Given this list of marker genes RFLNA, SMAD3, NELL1, BMPR2, SOX9, BMP2K, SLC20A2, ECM1, ALOX5, AMTN, NOTCH1, MGP, ADGRV1, DMP1, TENT5A, TXLNG, ISG15, STATH, COMP, ROCK1, BMP2, WNT4, LTBP3, CEBPB, CCL3, BMP7, BCOR, ZMPSTE24, SRGN, FZD9, HEY2 (NCBI Gene Id 30830), TGFB1, PTN, CCN1, BMP4, ACVR2B, VDR, PHOSPHO1, PTK2B, GATA1, WNT10B, HEY1, BGLAP, LTF, RFLNB, KL, ADRB2 (adrenoceptor beta 2), ASPN, MATN1, CFTR, TWIST1, MIR208A, CYP27B1, ODAPH, ANKH, FAM20C (FAM20C golgi associated secretory pathway kinase), MEF2C, PKDCC, BMPR1B (bone morphogenetic protein receptor type 1B), AHSG, ACTN3, ENAM, NBR1, BMP6, ROCK2, MMP20, OSR2, ATP2B1, RXRA, SLC8A1, ENPP1, ATF4, ACVR1, NOTUM, OSR1, ADGRG6, SGMS2, DDR2, TRPM4, SLC4A2, NOS3, HIF1A, GAS6, ACVR2A, S1PR1 (sphingosine-1-phosphate receptor 1), PTH, FGF23, GREM1 (NCBI Gene Id 7947), SUV39H1, ANO6, AMELX, TFAP2A, IFITM5, FBN2, GPM6B, CCR1, WNT6, RXRB, FBXO5, P2RX7, TMEM119, BMPR1A, ATRAID, here is a description of the gene set: species: Homo sapiens Any process that modulates the frequency, rate or extent of biomineral tissue development, the formation of hard tissues that consist mainly of inorganic compounds. Human Gene Set: GOBP_REGULATION_OF_BIOMINERAL_TISSUE_DEVELOPMENT